The following is a description of a gene set: The assembly of a synapse at a neuromuscular junction. Mouse Gene Set: GOBP_SYNAPTIC_ASSEMBLY_AT_NEUROMUSCULAR_JUNCTION species: Mus musculus, and this is the list of marker genes: Kcnj8, Pdzd11, Musk, Lin7b, Agrn, Six4, Large1, Gsk3b, Mycbp2, Colq, Lrp4, Lin7c, Lin7a, App, Six1